The following is a description of a gene set: This event has been computationally inferred from an event that has been demonstrated in another species.<p>The inference is based on the homology mapping from PANTHER. Briefly, reactions for which all involved PhysicalEntities (in input, output and catalyst) have a mapped orthologue/paralogue (for complexes at least 75% of components must have a mapping) are inferred to the other species. species: Mus musculus part of: Apoptotic execution phase Reactome Pathway: Apoptotic cleavage of cellular proteins electronically inferred by orthology from the curated human pathway, and this is the list of marker genes: Ctnnb1, Cdh1, Vim, Fnta, Casp8, Ptk2, Sh3glb2, Mapt, Add1, Casp7, Lmnb1, Bcap31, Dsg3, Casp3, Gas2, Lmna, Casp6, Gsn, Ocln, Stk26, Dsg1a